Given this list of marker genes TNF (tumor necrosis factor), CSNK1D, ESR1, TREX1, KCNK18, EDNRA, CACNA1A, here is a description of the gene set: species: Homo sapiens Human Gene Set: HP_MIGRAINE_WITHOUT_AURA Migraine without aura Repeated headache attacks lasting 4-72 h fulfilling at least two of the following criteria: 1) unilateral location, 2) pulsating quality, 3) moderate or severe pain intensity, and 4) aggravation by or causing avoidance of routine physical activity such as climbing stairs. Headache attacks are commonly accompanied by nausea, vomiting, photophobia, or phonophobia.